Given this list of marker genes KATNIP, EPAS1, ANP32A, DCAF6 (DDB1 and CUL4 associated factor 6), TLE1, ANKRD28, MRAS, JOSD1, NUAK1, TSC22D1, AAK1, KLC1, SMOX, ABL1, C1QB, SLC6A20, SYPL1, PPP1R3C, SIVA1, TOB1, GDE1, DERL1, RRS1, DYNC1LI1, ZFX, HMOX1, CENPM, UMPS, ENO2, ELF1, TMPRSS4, PHF20, LORICRIN, NCAPH, WWC1, AREG, NLRP2, ERMAP, TNFRSF11A, ZBTB1, ZNF500, FRS2, RASSF2, CDK19, AMIGO2, MOGS, NDRG1, C3orf18, CYTH1, SGK1, AKIRIN1, SOCS6, PALLD, ALCAM, EMP3, PPFIBP2, AIRE, UNC93B1, PDGFD, NDRG2, MYH11, EVC, IGSF3, RAP1GAP, IRF2BP1, PRPS1, MARCHF7, SOX9, WDR91, LRRC8D, H4C2, NUP50, UFL1, PROC, RHBDF1, RPS6KA3 (ribosomal protein S6 kinase A3), MAGEL2, NACC2, MEGF9, TMEM248, GET1, TRPC4AP, MTFR1, TBCC (NCBI Gene Id 6903), SPIDR, ZNF428, MGAT3, TRAF4, CAVIN2, HADHB, RFC1, DEPDC1, RNASEL (ribonuclease L), GSPT2, ZMIZ1, HOOK1, SOX4, GRB10 (growth factor receptor bound protein 10), GALNT10, DESI2, GLCE, TAF6, CERK, PLAA, ITPA, ETS2, CSNK2A1, NIN, SLC39A14, SERPINA3, ODC1, SYNE1, MYBL1, TST, BLVRB, PGM1, COTL1, SLC3A1, HERC5 (HECT and RLD domain containing E3 ubiquitin protein ligase 5), DDX27, GNAI1, SLC6A9, IKZF3, TNFRSF10B, NKX2-2, TSN, C6orf120, MYH7B, RRAS (NCBI Gene Id 6237), APPL2 (NCBI Gene Id 55198), STARD3, TP53AIP1, TGFA, RPRD1A, NDUFB5, FER, DLC1, ZCCHC14, RHOF, IQSEC1, ATP2B4, CDC25C, CXCR5, ZBED5, CCND3, TBCD, CEPT1, PPARG, SLC20A1, HBEGF, MBNL2, APOA4, JARID2, CERT1, RYK, CCN2, HNRNPA0, AP1S2, ATP9A (ATPase phospholipid transporting 9A (putative)), GOT2, SRSF1, SDC3, FFAR2 (free fatty acid receptor 2), SLC29A3, NDRG3, SHOX2, WBP4, MRPL57, KIAA0513, ZFAND5, GATA3, EPB41L4A-DT, MEX3C (NCBI Gene Id 51320), NFKBIE, APOO, AKTIP, OSBPL9, NBR2, METTL9, ORAI3, BRWD1, TGFBR2, DNM3, VAMP3, BHLHE40, TMEM106C, SLC41A3, TJP1, ABR, TBC1D17, ARHGEF2, SMARCA5, NRAP, TLE3, MRC1, RGS11 (NCBI Gene Id 8786), TFE3, DNAJB12, PLEKHG3, HMG20B, here is a description of the gene set: from publication Toker A, Engelbert D, Garg G, Polansky JK, Floess S, Miyao T, Baron U, Düber S, Geffers R, Giehr P, Schallenberg S, Kretschmer K, Olek S, Walter J, Weiss S, Hori S, Hamann A, Huehn J (PMID 23420886) Human Gene Set: GSE42021_CD24HI_VS_CD24INT_TCONV_THYMUS_UP species: Homo sapiens We investigated at which stage of maturation commitment to a stable Foxp3-expressing phenotype takes place. We assessed stability of Foxp3 expression in thymic Foxp3+ Treg subsets of different maturity, defined by CD24 expression. Next we compared gene expression profiles of Foxp3+ Treg subsets (+) of different maturity (24lo, 24int, 24hi) and could identify a set of genes that were specifically up or downregulated in Foxp3+ Tregs, but not in Foxp3- conventional T cells, in a maturation-dependent manner. Genes up-regulated in thymic T conv: CD24 high versus CD24 int.